Given this list of marker genes RIIAD1, LYPD2, FSCN2, NOS1 (NCBI Gene Id 4842), CAMK2A, PCDHB5 (protocadherin beta 5), PALMD, FGF6, KRT26, BAHCC1, DNAJB8 (NCBI Gene Id 165721), SLC26A5, SLITRK2, PDHA2 (NCBI Gene Id 5161), SLC2A9 (solute carrier family 2 member 9), TEX13B, DMRTC1, TRPM1, TRMT2B, PCDHB10, SSTR2, ADAM1A, RCVRN, KRT27, TSSK2, CNGA4, C10orf67, CRYGA, RPH3A, CES5A, ABCC9, GOLGA7B, SH3D19, TMEM174, TEX11 (testis expressed 11), DPEP3, LY6K, MFAP2, OLFM3, PCDHA9, CACNG2, AHRR, JPH2, RBM28, PIWIL1, TBX22, TNFRSF9, GIGYF1, CCDC110, EDAR, PSD3, FXYD2, RASGRP3, MGAT4D, IL20RB (NCBI Gene Id 53833), DUSP13B, ASZ1, PLCE1, TEX101, SPIRE1, RHO, SST, NSMCE3, BRDT, SYP, TRPC3, here is a description of the gene set: We report the application of single-molecule-based sequencing technology for high-throughput profiling of histone modifications in mammalian cells. By obtaining over four billion bases of sequence from chromatin immunoprecipitated DNA, we generated genome-wide chromatin-state maps of mouse embryonic stem cells, neural progenitor cells and embryonic fibroblasts. We find that lysine 4 and lysine 27 trimethylation effectively discriminates genes that are expressed, poised for expression, or stably repressed, and therefore reflect cell state and lineage potential. Lysine 36 trimethylation marks primary coding and non-coding transcripts, facilitating gene annotation. Trimethylation of lysine 9 and lysine 20 is detected at satellite, telomeric and active long-terminal repeats, and can spread into proximal unique sequences. Lysine 4 and lysine 9 trimethylation marks imprinting control regions. Finally, we show that chromatin state can be read in an allele-specific manner by using single nucleotide polymorphisms. This study provides a framework for the application of comprehensive chromatin profiling towards characterization of diverse mammalian cell populations. Genes with high-CpG-density promoters (HCP) without H3 methylation marks at K4 and K27 in embryonic stem cells (ES). species: Mus musculus Human Gene Set: MIKKELSEN_ES_HCP_WITH_H3_UNMETHYLATED from publication Mikkelsen TS, Ku M, Jaffe DB, Issac B, Lieberman E, Giannoukos G, Alvarez P, Brockman W, Kim TK, Koche RP, Lee W, Mendenhall E, O'Donovan A, Presser A, Russ C, Xie X, Meissner A, Wernig M, Jaenisch R, Nusbaum C, Lander ES, Bernstein BE (PMID 17603471)